The following is a description of a gene set: Mouse Gene Set: GOCC_MYOFILAMENT studied in species Mus musculus Any of the smallest contractile units of a myofibril (striated muscle fiber)., and this is the list of marker genes: Tmod3, Tnnt3, Neb, Tpm2, Mybphl, Trim32, Lmod2, Tmod1, Tpm1, Acta1, Obscn, Ttn, Tnnc1, Tmod4, Mybpc3, Fhod3, Tnni1, Lmod3, Actn2, Tnnc2, Tnnt1, Actn3 (actinin alpha 3), Lmod1 (NCBI Gene Id 93689), Tnni3, Tmod2, Tnni2, Tnnt2